Given this list of marker genes KL, CHN2, APBB1IP, PIP4K2A, ZNF277, HERPUD1, MIS18BP1, GNGT2, CACUL1, ARHGAP45, PMFBP1, S100Z, ZMYND12, F13A1, IST1, RNF130, SDS, DDX17, CA11, TTC7A, BAZ2B, TREM2, DERA, SPIDR, ZFHX3, MEF2C, SLC24A4, HPS3, TMEM134, TM7SF3, CLEC3B, SELENOP, AVPI1, AIG1, SPATA7, RNASE4, ASAH1, SORBS3, TPP1, CPVL, AATBC, CARD16, SPOPL (NCBI Gene Id 339745), RAP1GAP2, KCNMB4, CRLF3, EPRS1, CEP350, ALAD, MIF4GD, AHNAK, FMO4, ATP5IF1, PAM, CYBRD1, PFDN5 (prefoldin subunit 5), SLC39A10, STARD13, DEPTOR, RAD51AP1, RAB42, MARF1, CFD, ANG, PRRG4, M1AP, FAM13A, FGD2, EPAS1 (NCBI Gene Id 2034), TMEM59, CNOT8, PTPN18, LINC00957, CD1D, GSTK1, FAM228B, ACSL6, CEBPD, CTSS, HGF, ITGA4, FZD2, BLVRB, LINC00865, GUSBP3, ZBED3, PPP1R21, PTGR3, LINC00324, PIK3R1, RASA1, JPT1, CCDC14, TPK1, BTD, HAL, ABHD14A, GPNMB, C5, RB1, LY86, CD180, ECHDC1, DUSP3 (dual specificity phosphatase 3), CLEC10A, ABCC5, SNX18, IQCD, MAML3, RNASET2, FRMD4B (NCBI Gene Id 23150), BNC2, MNDA, ANGPT1, PLA2G15, NUPR1, DPEP2, ASRGL1, POLB, SULT1A1, SLC2A9, FCGR2B, HSPBAP1, APOBEC3C, ITFG2, CASP10, PAQR8, LPAR6, SLC49A4, CCSAP, CHST13, CRHBP, SIGLEC15, OGFRL1, LINC02035, VPS39, TLR7, GGTA1, HADHB, EXOC1, MPP1, TMT1A (thiol methyltransferase 1A), SPIN1, FMO5, GINS1, SHMT1, CD46, CCNY, SNX29, CIITA, PTBP3, HEXA, STMN1, SIPA1L1, NHLRC3, ACRBP, PCTP, MDM4, TESK1, MS4A6A (NCBI Gene Id 64231), RIN3, APOC1, GDPD1 (NCBI Gene Id 359824), STK38 (NCBI Gene Id 11329), ERP29 (endoplasmic reticulum protein 29), ARHGEF6, ZBTB1, UNC5CL, ADA2, PLCB1 (NCBI Gene Id 23236, phospholipase C beta 1), ATP6V0A1, FABP4, RCBTB2, SLC35A1, BACE1, CAPN3, VPS8, LTC4S, TNFSF13B, ACP5, ADHFE1, FXYD6, MBNL2, HHEX, GRN, TASOR, NR4A2, GAS2L3, SLC7A8, NFXL1, RNF135, TRIOBP, NMNAT3, ITGA9, TUT7, ZNF395, MKRN1, here is a description of the gene set: species: Homo sapiens Histone methyltransferases catalyze site-specific deposition of methyl groups, enabling recruitment of transcriptional regulators. In mammals, trimethylation of lysine 4 in histone H3, a modification localized at the transcription start sites of active genes, is catalyzed by six enzymes (SET1a and SET1b, MLL1–MLL4) whose specific functions are largely unknown. By using a genomic approach, we found that in macrophages, MLL4 (also known as Wbp7) was required for the expression of Pigp, an essential component of the GPI-GlcNAc transferase, the enzyme catalyzing the first step of glycosylphosphatidylinositol (GPI) anchor synthesis. Impaired Pigp expression in Wbp7-/- macrophages abolished GPI anchor-dependent loading of proteins on the cell membrane. Consistently, loss of GPI-anchored CD14, the coreceptor for lipopolysaccharide (LPS) and other bacterial molecules, markedly attenuated LPS-triggered intracellular signals and gene expression changes. These data link a histone-modifying enzyme to a biosynthetic pathway and indicate a specialized biological role for Wbp7 in macrophage function and antimicrobial response. Genes down-regulated in bone marrow-derived macrophages treated with LPS for 4h: heterozygous versus homozygous knockout of MLL4. Human Gene Set: GSE30971_WBP7_HET_VS_KO_MACROPHAGE_4H_LPS_STIM_DN from publication Austenaa L, Barozzi I, Chronowska A, Termanini A, Ostuni R, Prosperini E, Stewart AF, Testa G, Natoli G (PMID 22483804)